The following is a description of a gene set: from publication Chen Y, Wang X (PMID 31504780) Genes predicted to be targets of miRBase v22 microRNA mmu_miR_17_5p in miRDB v6.0 with MirTarget v4 prediction scores > 80 (high confidence targets). Mouse Gene Set: MIR_17_5P species: Mus musculus, and this is the list of marker genes: Arhgef11, Rs1, Rps6ka5, Mier1, Ahrr, Gxylt1, Pkd1, Cbln4, Fbxl5, Pgm2l1, Glis3, Hycc2, Lypd6, Mylip, Nr4a3, Sertad2, Psd, Rap2c, Snx16, Nfat5, Zfpm2, Pitpna, Pafah1b1, Frmd6, B3galt2, Rab30, Oxr1, Dnajc24, Pthlh, Lrrc55, Mfn2, Kif5a, Mapk4, Tmed8, M6pr, Tbcel, Lrch1, Tasor, Zfand4, Slc17a7 (NCBI Gene Id 72961), Nanos1, Klf11, Tbc1d9, Arhgap35, Fat2, Pde3b, Pak5, Sash1, Iqsec2, Napepld, Lima1, Plxdc2, Rnf2, Ahnak, Kdm2a, Rb1cc1, Cnot6l, Rgs17, Suco, Ppp1r3b, Map7, Pkn2, Tle4, Smim5, St6galnac3, Rb1, Zfp148, Txnip, Flt1, Ugdh, Cmpk1, Mmp24, Tnks1bp1, Ssh2, Mtmr3, Cd69, Dusp2, Nbea, Prrg1, 6430548M08Rik, Gabbr2, Sar1b, Ccng2, Fibin, Enpp5, Rab5b, Chd9, Pbx3, Hs3st5, Pcsk5, Wdfy3, Fzd3, Srpk2, Sorl1, Atad2, Tgfbr2, Mospd2, Rps6ka4, Ezh1, Midn, Purb, Dsg4, Chrm2, Trappc2, Pgbd5, Cep120, Pdgfra, Rab10, Stxbp5, Bahd1, Dpysl5, Bmpr2, Crk, Gpr137b, Fam13c, Marchf8, Prr14l, Bcl11b (B cell leukemia/lymphoma 11B), Idua, Mosmo, Zfp367, Ccdc71l, Rassf2, Zdhhc8, Lrp8, Panx2, Rnf6, Fbxo28, Adam9, Akt3, Tafa1, Acsl4, Ptpn21, Npat, Zbtb9, Pcdha12, Hlf, Map3k13, Mex3d, Ago1 (NCBI Gene Id 286948), Usp32, Limk1, Slc12a7, Frs2, Rps6ka1, Fastk, Chmp4c, Pcdha11, Klf9, Sh3bp2, Pcdha2, Retreg3, Gpr63, Pcdha4, Nr2c2, Pcdha10, Pls1, Atl3, Rasd1, Uevld, Ncoa3, Osm, Usp24, Tnfaip1, Sema7a, Map3k8, Ldlrap1 (NCBI Gene Id 230816), Unc80, Dnal1, E2f5, Irf9 (interferon regulatory factor 9), Wfs1, Dcbld2, Ptpn4, Ddhd2, Arid4b, Mink1, Slc40a1, Zfp827, Rab11fip5, Mcl1, Mknk2, Prepl, Afg1l, Zfp9, Pdcd1lg2, Smoc2, Scn1a, Dmtf1, Sfmbt1, Trim3, E2f1, Tspan9, Ankrd52, Bicd2, Plekha3, Gab1, Cfl2, 1600012H06Rik (NCBI Gene Id 67912), Nckap5, Btg3 (NCBI Gene Id 640416), Atg14, Npas2, Kmt2a, Pcdha7 (NCBI Gene Id 12939), Tbc1d12, Itpripl2, Gosr1, Tars2, Slc22a23, Jazf1, Vangl1, Ginm1, Irf2bp2, Ankib1, Heg1, Pkd2l2, Cnot7, Rasgrf2, Sobp, Fgd4, Has2, Nek9, Camk2n2 (calcium/calmodulin-dependent protein kinase II inhibitor 2), Camta2, Coro2b, Rab22a, Rasl11b, Zfyve26, Tet1, Trappc14, Ogfod2, Phip, S1pr1 (NCBI Gene Id 99736), Ankrd33b, Derl2, Kcnb1, Lpgat1, Dock4, Gid4, Ppp1r15b, Pcdhac1, St8sia2, Timp2, Slc25a40, Tmem64, Csrnp3, Slc31a2, Pcdha6, Rundc1, Klhl28, Slc24a2, F3, Ntng1, Zbtb41, Dpysl2, Kat2b, Pcdha3, Rsbn1, Epha4, Cast, Ulk1, Ythdf3, Tfb2m, Pcdha5, Trip10, Tnks2, D030056L22Rik, Pcdha9, Trpv6, Arhgef18, Ppp1r3e, Srgap1, Sqstm1, Arhgap1, Bbx, Znfx1, Map6d1 (MAP6 domain containing 1), Pcdha1, Neurog3 (NCBI Gene Id 216015), Vash2, Xrn1, Ism2, Fat4, Mastl (NCBI Gene Id 98167), Zfp704, Aak1, Rab8b, Ube2q2, Kpna2, Reep3, Csnk1g1, Nagk, Rcan3, Olfm1, Zdhhc1, Col4a4, Arhgap26, Polr3g, Kif23, Ankrd13c, Wdr37, Stx6, Rbbp7, Retreg2, Naa30, Cc2d1a, Map3k2, Zfp800, Ano5, Skor1, Gramd1a, Prr15, Brms1l, Slc16a9, Spred1, Slc18a2, Atxn7l1 (NCBI Gene Id 72174), St3gal1, 2510009E07Rik, Kcnq2 (potassium voltage-gated channel, subfamily Q, member 2), Itgb8, Rest, Zfp661, Atxn1l, Col4a3, Smad5, Laptm4a, Srcin1, Reps2, Lama3, Rgmb, Bnip2, Zhx2, Zbtb18, Rhoc, Dennd5b, Rp2, Kmt2b, Snx8 (NCBI Gene Id 338537), Creb1 (NCBI Gene Id 98624), Plekha7, Zfp91, Unk, Ptpn3, Rsrp1, Hook3, Luzp1, Pxk, Fyco1, Topors, Fsd1l, Zfp236, Myt1l (myelin transcription factor 1-like), Armc8, Fgd5, Aktip, Unkl (NCBI Gene Id 74154), Ormdl3, Akap13, Fcho2, Eif4a2, Myf5, Ano3, Sos1, Creb5, Zc3h12c, Pfkp, Zfp512b, Pcdhac2, Btbd10 (BTB domain containing 10), Gon4l (gon-4 like), Dennd10, Hbp1, Elk3, Rbl2, Smyd1, Fjx1, Ankrd17 (NCBI Gene Id 81702), Pkd2, Fam219b, Ppp1r21, Arhgef10, App, Apcdd1, Slc16a6, Tmcc3, Trip11, Eri1, St6galnac6 (ST6 (alpha-N-acetyl-neuraminyl-2,3-beta-galactosyl-1,3)-N-acetylgalactosaminide alpha-2,6-sialyltransferase 6), Susd6, Kcnk10, Rapgefl1, Trim36, Map3k12, Rufy2, Nrip3, Lhx6, Zbtb4, Slc2a4, Agfg2, Mapre3, Dab2, Atg16l1, Mfap3l, Rab33b, Tmem127, Il25, Usp3, Gpr137c, Ddhd1, Sall3, Rnf150, Tmem267 (NCBI Gene Id 633640), Cep57, Ptchd4, Uri1, Sybu, Rgma, Tsg101, Jpt1, Ankrd9, Usp46, Sumf1, Mkrn1, Abca1, Nup35, Sema4b, Cep97, Clip4, Pex5l, Tph1, Spopl, Kif3b, Gpc6, Smoc1, Nabp1, Tnfrsf21, Rnf128, Foxj3, Bnc2, Abcg4, Nedd4l, Osr1, Tbc1d8b, Ints14, Ube3c, Arhgap12, Fnbp1l, Map3k14, Sall1, Tanc2, Tiam1, U2surp, C2cd2, Med12l, Slc49a4, Sh3pxd2a, Crybg3, Ndel1, Slc17a8, Clock, Pcdha8, Septin2, Epha7, Crot, Egln3, Cdca7, Acer2